The following is a description of a gene set: species: Mus musculus This event has been computationally inferred from an event that has been demonstrated in another species.<p>The inference is based on the homology mapping from PANTHER. Briefly, reactions for which all involved PhysicalEntities (in input, output and catalyst) have a mapped orthologue/paralogue (for complexes at least 75% of components must have a mapping) are inferred to the other species. Reactome Pathway: HDR through MMEJ (alt-NHEJ) part of: Homology Directed Repair electronically inferred by orthology from the curated human pathway, and this is the list of marker genes: Brca2, Polq, Rad52, Nbn, Rbbp8, Xrcc1, Mre11a